Given this list of marker genes Gabrg2, Otud7b, Antxr1, Ppp4r1, Afap1, Taf3, Sat1, Sox21, Cand1, Chsy3, Slfn14, Borcs8, Wdr26, Tiparp, Grb7, Zfp729a, Nsd3, Rragc, Gmps, BC048679, Scube2, Slc30a7, Gng5, P2rx2, Zfp65, Nkapl (NFKB activating protein-like), Nampt, Itprid2, Ppp1r15b, Bsph1, Gpr137c, Spdya, Oprl1, Olig3, Gm10778, Igf1r, Kmt2e, Tnrc6b, Etnk1, Onecut2, Btbd2, Nsa2, Omg, Stx8, Aff2, Nr3c1, Usp14, Mindy2, Nxpe3, Stmn4, Snx21 (NCBI Gene Id 70479), Zfp738, Rfx3 (NCBI Gene Id 320548), Cntn4, Man1a, Lmo7, Arrdc3, Cdkl2, Esco1, Stard13, Traf3, Ccdc127, Plaur, Zfp97, Sash3, Zfp960, Dcc, Rb1cc1, Srsf11, Prkag2, Osbpl8, Mc2r, Dock5, Gulp1, Arl2bp, Dip2b, Arc, Palb2 (NCBI Gene Id 233826), St13, Gpr12, Slc49a4, Ezh2, Csgalnact2, Hhla1, here is a description of the gene set: from publication Chen Y, Wang X (PMID 31504780) Genes predicted to be targets of miRBase v22 microRNA mmu_miR_7646_3p in miRDB v6.0 with MirTarget v4 prediction scores > 80 (high confidence targets). species: Mus musculus Mouse Gene Set: MIR_7646_3P